Given this list of marker genes Procr, Fga, F12, C1qbp, F8, F13a1, Serpine2, Prcp, F10, Fgg, Serpinc1, Prtn3, F5, A2m (NCBI Gene Id 232345), F3, Cd177, Klkb1, Proc, Vwf, Pros1, Gp5, Pf4, Thbd, Kng2, Gp1ba, Gp9, F9, Serpind1, Fgb, Tfpi, Gp1bb, F2r, F2, Serping1, F13b, F11, Serpina5, F7, here is a description of the gene set: Mouse Gene Set: REACTOME_FORMATION_OF_FIBRIN_CLOT_CLOTTING_CASCADE studied in species Mus musculus Formation of Fibrin Clot (Clotting Cascade)